Given this list of marker genes Cyp2c66 (cytochrome P450, family 2, subfamily c, polypeptide 66), Cyp1a1, Cyp4a12b, Cyp1b1, Cyp1a2, Cyp2c65, Cyp2u1, Cyp4f15, here is a description of the gene set: Mouse Gene Set: REACTOME_SYNTHESIS_OF_16_20_HYDROXYEICOSATETRAENOIC_ACIDS_HETE Synthesis of (16-20)-hydroxyeicosatetraenoic acids (HETE) studied in species Mus musculus